The following is a description of a gene set: Human Gene Set: OCT1_07 Genes having at least one occurrence of the motif TNTATGBTAATT in the regions spanning 4 kb centered on their transcription starting sites. This matches the POU2F1 transcription factor binding site V$OCT1_07 (v7.4 TRANSFAC). studied in species Homo sapiens, and this is the list of marker genes: ODAPH, ESRRG, NUDT3, HDAC9, NR2F1, LRFN5 (leucine rich repeat and fibronectin type III domain containing 5), DTNA, TOB1, GRHL2, NDP, NOL4L, IGF2-AS, BACE2, FGFR2, FRMD4A, MAP3K20, ZIC1 (NCBI Gene Id 7545), LMO4, KIF3B, SEMA5B, LYRM1, BCL11B, TGM3, ZIC4, COMMD10, NEUROD6, NFIA, CCDC14, CADM1, NUDT6, HS6ST2, MBP, GDI1, HOXD9, STOML2, FOXB1, C2CD5 (C2 calcium dependent domain containing 5), BTBD3, CDK14, SALL3, ASXL1, HNRNPH1, RFTN2, CD36, C7orf33, TRAF3, WNT11, SCOC, XYLT2, GRHL3, RAB26, NEK10, CSF3, ITSN1, CCND1, MTUS1, LINC00470, PLEKHA6, SLA, C17orf58, HOXA10, NEIL3, DCUN1D3, MGAT4C, NXPH1 (NCBI Gene Id 30010), SCML4, HOATZ, MAGEE2, IL17F, CNTNAP4 (NCBI Gene Id 85445), NFIX, SCRN1, HEPH, CD79B, ELP4, LAMP5, BARHL2, RANBP6 (NCBI Gene Id 26953), PLCB1, TRERF1, KRTAP11-1, MYO18A, CABCOCO1, ZNF148, ATM, PRR34, ELAVL4, RUNX1T1, KCNQ5, NEO1, ATOH1, FAM50A, CPEB4, TNNI3K, GPR85, ISL1, FOXP2, NPHP4, PRICKLE2, TSPYL2, NOS1, RALGPS2, NEDD4, FAM98A, TMOD2, ATP13A4, UBE3A, TMTC2, KMT2C, ADORA2A, USP28, CCDC91, PTGR3, ZBTB10, RCAN1, NUBPL, CRYZL1, FGF11, ZNF271P, ETV1, POU3F4, CSNK1G1, TUBB4A, CSN1S1 (NCBI Gene Id 1446), PHOX2B, CCDC80, HEPACAM, BDNF, FBXL19-AS1, MID1, TBXAS1, SALL1, ANKRD11, ADD3, IMMP1L, PTPN22 (protein tyrosine phosphatase non-receptor type 22), IRAK1, IL25 (NCBI Gene Id 64806), RARB, ABL2, CXADR, FOXN3, IRX2-DT, PDZRN4, PABIR3, COLCA1, KCNQ1DN, FAM53B, SERTAD4, KCNN3 (NCBI Gene Id 95947), BCOR, SOX3, SKIDA1, SLC25A13, IRX2, RUNX1, IRX4, FAM53C, CAMKV, JAZF1, MYT1, CLVS1, FZD4, BRD8, EN1, LDB2, DIXDC1, MKS1